The following is a description of a gene set: Human Gene Set: GOBP_FC_RECEPTOR_MEDIATED_INHIBITORY_SIGNALING_PATHWAY The series of molecular signals generated as a consequence of the binding of the Fc portion of an immunoglobulin by an Fc receptor capable of inhibiting an immune effector process contributing to an immune response. The Fc portion of an immunoglobulin is its C-terminal constant region. species: Homo sapiens, and this is the list of marker genes: LILRB1, PSG9, LYN, LILRB2, LILRB4 (NCBI Gene Id 11006)